The following is a description of a gene set: studied in species Mus musculus Mouse Gene Set: REACTOME_CYTOKINE_SIGNALING_IN_IMMUNE_SYSTEM Cytokine Signaling in Immune system, and this is the list of marker genes: Il31, Usp18, Map2k4, Csf1, Rps27a, Sphk1, Dusp4 (NCBI Gene Id 70236), Psmc2, Il24, Sqstm1, Tnfsf15 (tumor necrosis factor (ligand) superfamily, member 15), Adar, Ifnar1, Mapk3, Kras, Nck1, Peli1, Il1r2, Psmc6, Tarbp2, Grb10, Socs5, Cntf, Stat5b, Il18rap, Jak2, Ifna12, Tubb6, Pde12, Csf2, Psmd7 (NCBI Gene Id 17463), Hspa1l (NCBI Gene Id 15482), Il18, Mapk10, Creb1, Tuba1a, Sos1, Map2k6, Tnfrsf18, Cd40, Nedd4, Il3, Ager, Il12rb1, Tnfrsf1a, Tbk1, Ifng, Irf9, Npm1, Tnfrsf11a, Tubb1, Csf1r, Shc1, Irak1, Ilf3, Eif4e3 (NCBI Gene Id 66892), Mapk1, Grb2, Ptk2b, Ifna9, Ube2m, Casp1, Abce1, Rigi, Traf3, Psmd2, Kpnb1, Akt2, H3c7, Grap2, Adrm1, Rnf7, Ube2d3, Raf1, Prl, Il1rapl1, Prkcd, Rapgef1, Irak3, Eif4g3, Il12rb2, Sdc1, Il6ra, Csf2rb2, Ifna11, Psmd12, Ifna14, Ifna7, Xiap, Psmd11, Fancg, Psmd8, Fyn, Il12b, Il18r1, Kpna1, P4hb, Rps6ka5, Il22, Ppp2r1b, Tab1, Tubb2b, Pik3cd, Tnfrsf11b, Flt3l, Vrk3, Psmc4, Map3k3 (mitogen-activated protein kinase kinase kinase 3), Psmd6, Psmc3, Prkaca, Sos2, Tuba1b, Il6, Pik3r3, Eloc, Tnfsf13b, Hras, Ltbr, Uba3 (NCBI Gene Id 319310), Psmb4, Fancf (NCBI Gene Id 330538), Smarca4, Osmr, Rps6ka2, Osm, Tnfsf9, Psma2, H3c11, Il13, Il13ra1, Dhx9, Il36g, Nkiras2, Ikbkb, Faap20, Ifna16, Pik3cb, Ppp2ca, Cdkn1b, Prkra, Prlr, Psmc5, Psmb5, Dusp3, Il5, Cd27, Eif4g2, Ebi3, Pik3r2, Il18bp, Il21, Psmd1, Socs2 (suppressor of cytokine signaling 2), Akt3, Ubc, Psmb7, Peli3, Fkbp5, Tnfrsf8, Ppp2r5a, Tnfrsf1b, Lrrc14, Ifngr1, H3c2, Nod2, Relb, Tab3, Csk, Rps6ka3, Tubb3, Ghr, Il19, Ppp2r5d, Il22ra2, Map3k7, Eif4e2, Traf6, Il27ra, Il34, Nkiras1 (NCBI Gene Id 69721), Il9r, Camk2d, Ywhaz (NCBI Gene Id 68643), Dusp7, Rbx1, Il36b, Il1rap, Tubb2a, Tnfsf14, Ppm1b, Chuk, Syk, Ifi44, Lck, Ifna1, Fanca, Irs2, Foxo3, Sumo1, Traf2, H3c3, Ifna4, Canx, Il33, Map2k3, Psmb2, Ifnab, Hspa1b, Ptpn6, Tubb4a, Ube2v1, Mapk14, Tslp, Ctf1, Camk2b, Mapk8, Trim25, Stxbp2, Fance, Psmc1, Ube2d2a, Tuba3a, Psma1, Mapkapk3, Plcg1, Inppl1, Psma5, H3c15, S100b, Psma6 (NCBI Gene Id 26443), Il31ra, Ifnl3, H3c6, Pik3r1, Psma4, Hspa2, Tab2, H3c8, Cul1, Ubb, Eif4a2, Tnfrsf13b, Eif4g1, Gsdmd, Ptprj, Uba7, Mapk7, Cd40lg, Brwd1, Cenpx, Il12a, Tifa, Il27, Faap24, Il13ra2, Tnfsf13, Rela, Ube2n, Socs1, Il10, Stat3, Isg15, Map3k14, Faap100, Lyn (LYN proto-oncogene, Src family tyrosine kinase), H3c13, Fancm, Cntfr, Rnasel, Nfkb1, Csf3, Hck, Cd4, Tnfsf12, Dnajc3, Psmd13, Il16, Uba52, Stx4a, Il1rl1, Il1rn (interleukin 1 receptor antagonist), Nfkbia, Stx3, Psmd3, Tuba3b, Irf3 (interferon regulatory factor 3), Lif, Becn1, Il1f10, Ube2e1, Abl2, Peli2, Fancb, Il10ra, Cd70, Ptprz1, App, Birc2, Tnfrsf4, Psmb3, Il36a, Ifna15, Il23r, Dusp6, Ifnar2, Cbl, Txlna, Ube2l6, Stx1a, Skp1, Hspa1a, Ifngr2, Uba52rt, Clcf1, Ptpn2, Map2k7, Edaradd, Il15, Eif2ak2, Ifnb1, Mapt, Cdk1, Il2rb, Il4, Nfkbib, Eif4a1, Il15ra, Il1b, H3c4, Il20ra, Sh2b1, Il23a, Tubb4b, Hmgb1, Stat2, Ctsg, Tnfrsf17, Eif4e, Vamp2, Crlf1, Ube2d1, Gh, Tuba1c, Cenps, Socs3, Sh2b3, Tnfrsf12a, Tubal3, Ppp2cb, Fos, Tuba4a, Psma7, Camk2g, Pias1, Stat5a, Csf2rb, Il10rb, Ifna13, Ybx1, Ifi44l, Il7, Il1r1, Ptpn1, Tnfsf8, Lta, Il6st, Socs6, Tnfrsf14, Ripk2, Map3k8, Fbxw11, Ptpn11, Nfkb2, Pik3ca, Snap25, Nod1, Elob, Psmd14, Il11, Myd88, Yes1, Tnfsf4, Irak2, H3c14, Mapkapk2, Edar, N4bp1, Lifr, Il7r, Il4ra, Casp3, Ifnl2, Tnf, Camk2a, Rps6ka1, Arih1, Usp14, Birc3, Stat6, Ltb, Atf2 (NCBI Gene Id 97033), Ifna2, Il1a (interleukin 1 alpha), Mapk11, Dus2, Il1rl2, H3c10, Trp53, Mx2, Tuba8, Il2, Nlrc5, Tnfsf11, Casp8, Mavs, Il5ra, Tnfrsf13c, Ilf2, Akt1, Atf1, Il9, Crkl, Il20rb, Inpp5d, Il11ra1, Tnip2, H3c1, Ifna6, Hspa8 (heat shock protein 8), Tyk2, Fancl, Il36rn, Psma3, Irak4, Eda2r, Nlrx1, Tnfrsf9, Oasl1, Il22ra1, Psmb6, Sla2, Mapk9, Vav1, Hsp90b1, Jun, Eda, Tollip, Snca, Il21r, Ifit1bl2, Il20, Eif4a3, Ifnlr1, Ikbkg, Crk, Il2ra, Il2rg, Ppp2r1a (protein phosphatase 2, regulatory subunit A, alpha), Fancc, Flnb, Sla, Alpk1, Tnfsf18, Psmb1, Ifna5, Tnfrsf25